Given this list of marker genes Apoe, Fasl, Serpinb3a, Aldoa, Ist1, Ppfia3, Arrdc4, Bhmt, Slc9a3, Rab5b, Gprc5d, Nsun2 (NCBI Gene Id 28114), Cd9, Slc11a2, Phospho1, Sdcbp, Muc1, Lamp2, Tmem98, Gars1, Syt4 (synaptotagmin IV), Car4, Rap2b, Cd86, Mir26a-1, Kif12, Pkd2, Aoc1l1, Defb1, Serpina5, Mir20a, Cd63, Aoc1, Sord, Mir106a, Ahnak, Slc30a3, Krt13, Mir20b, Sri, Alb, Mir26a-2, Rab11a, Rbmx, Gprc5a, Defb37, Peg10 (NCBI Gene Id 30899), Asah2 (N-acylsphingosine amidohydrolase 2), Cubn, Aoc1l2, Aqp1, Bhmt1b, Alpl, Clic1, Arc, Apoa1, Mir16-1, Tfrc, Scnn1b, Ap3b1, Icam1, Has2, Pkd1, Defb15, Hspa8, Cd47, Apoa4, Slc26a4, Hnrnpa2b1, Defb34, Mir195a, Serpine1, Snx18, Ddx11, Gbp7, Arrdc1, Acy1, Serpinb3b, Abcb6, Ybx1, Mir106b, Ago2, Qsox1, Aoc1l3, Ide, Actg1, Xpnpep2, Rbmxl1, Hspa4, Prom2, Gbp9, Mir16-2, Itga2b, Fn1, Gbp3, Pmel, Tsg101, Mir17, Serpinb3c, Hexd, Gbp6, Epcip, Slc2a4, Myoc, Hspd1, Dicer1, Scnn1g, Anpep, Naglu, Iigp1, Pdcd6ip, Apoa5, Slc12a1, Podxl, Vasn, Anxa1, Gprc5c, Plaa, Serpinb3d, Prom1, Pkhd1, Gbp2b, Mir451a, Aqp2, Ace, Adam15, Scnn1a, Slc12a3, Egf, Bloc1s6, Mir26b, Gbp2, Snapin, Rab4a, Bag6, Cd81, Gprc5b, Anxa2, Cd274, Bloc1s5, here is a description of the gene set: species: Mus musculus Organized structure of distinctive morphology and function, occurring outside the cell. Includes, for example, extracellular membrane vesicles (EMVs) and the cellulosomes of anaerobic bacteria and fungi. Mouse Gene Set: GOCC_EXTRACELLULAR_ORGANELLE